The following is a description of a gene set: Any process that modulates the frequency, rate or extent of the directed movement of potassium ions (K+) into, out of or within a cell, or between cells, by means of some agent such as a transporter or pore. species: Mus musculus Mouse Gene Set: GOBP_REGULATION_OF_POTASSIUM_ION_TRANSPORT, and this is the list of marker genes: Kcnh2, Cav1, Kcne2, Akap5, Bin1, Kcns2, Wnk2, Prnp (prion protein), Dlg1, Atp1b1, Kcng3, Kcnq1, Ano6, Kcnip3, Cav3, Trem2, Atp1b2, Hcrt, Kcnn2, Kcnf1, Atf4, Nedd4, Oxsr1, Atp1b3, Rgs4, Kif5b, Dpp10, Adrb2, Plcb4, Kcnj1, Lrrc38, Akap9, Kcnab1, Gck, Wnk4, Nppa, Vip, Vamp2, Kcnab2 (potassium voltage-gated channel, shaker-related subfamily, beta member 2), Neto1, Amigo1, Kcnc1, Akap6, Rnf207, Adora1, Kcnmb1, Dpp6, Oprk1, Ptk2b, Kcnip2, Lrrc26, Nos1, Edn3, Cckar, Cxcl1 (NCBI Gene Id 14825), Ank2, Itgb1, Cacna1d, Htr2a, Kcnj2, Kcne5, Actn2 (NCBI Gene Id 73715), Ywhae, Rgs7, Kel, Nos3, Kcnc2, Gal, Agrn, Lrrc55, Crbn, Nedd4l, Wnk1, Kcne3, Abcc8 (ATP-binding cassette, sub-family C member 8), Kcns1, Kcna5, Kcnip1, Kcnrg, Lrrc52, Galr2, Nr3c2, Cd63, Kcnip4, Adcyap1, Abcc9, Kcne1, Ank3, Gnaq, Drd3, Gnb2, Hbp1 (NCBI Gene Id 77235), Wwp2, Ptger3, Flna, Kcng4, Akap7, Sumo1, Grp, Casq2, Kcnab3, Wnk3, Stk39, Drd2, Kcng1, Fhl1